Given this list of marker genes ALDH1L1, MTHFD1, MTHFD1L, AASDHPPT, ALDH1L2, MTHFD2L, here is a description of the gene set: The chemical reactions and pathways involving 10-formyltetrahydrofolate, the formylated derivative of tetrahydrofolate. Human Gene Set: GOBP_10_FORMYLTETRAHYDROFOLATE_METABOLIC_PROCESS species: Homo sapiens